The following is a description of a gene set: RNA Polymerase III Transcription species: Homo sapiens Human Gene Set: REACTOME_RNA_POLYMERASE_III_TRANSCRIPTION, and this is the list of marker genes: GTF3A, POLR3H, CRCP, TBP, SNAPC3, BDP1, SNAPC4, POLR3GL, GTF3C6, NFIB, POLR2E, POLR3E, SNAPC1, BRF1, POLR3A, POLR3B, SSB, POLR2F, SNAPC2, POLR2K (RNA polymerase II, I and III subunit K), NFIA, POLR1C, ZNF143, NFIX, GTF3C2, BRF2, POLR2L, POU2F1, GTF3C5, POLR1D, GTF3C3, POLR3C, POLR3D, NFIC, GTF3C1, POLR2H, POLR3F, POLR3G, SNAPC5, POLR3K, GTF3C4